Given this list of marker genes AK7, AK6, AK4, AK5, AK3, AK1, AK9, AK2, AK8, here is a description of the gene set: Catalysis of the reaction: ATP + AMP = 2 ADP. Human Gene Set: GOMF_ADENYLATE_KINASE_ACTIVITY studied in species Homo sapiens